Given this list of marker genes Mxd4, Npc2, Tspan32 (NCBI Gene Id 56845), Id3, Rgs2, Lck, Utrn, Cxcr4, Ms4a4b, Ccnd3, Uba52, Cd52, Fau, Ptpn22, Rgs16, Pold4, Cd83, Cd3d, Ube2b, Ift80, Cdkn1b, Cd3g, Tsc22d3 (NCBI Gene Id 14605), Hcst, Grap, Cox7a2l, Rgs10, Il7r, Eif3h, Cd84, Dusp1, Trbc2, Txnip, Evl, Ephx1, Smpdl3a, Stap1, Igf1r, Smad7, Stk17b, Btg2, Pfdn5, Ucp2, H1f4, Jun, Fos, Ypel3, H1f2, Arhgap31, Adcy7, Cd27, Pnrc1, Smc4, Thap3, Ripor2, Itpkb, Fyb1, Sh2d1a, Cd69, Ms4a6b, Limd2, Btg1, Zfp36l1, here is a description of the gene set: from publication Cui A, Huang T, Li S, Ma A, Pérez JL, Sander C, Keskin DB, Wu CJ, Fraenkel E, Hacohen N (PMID 38057668) species: Mus musculus Genes negatively differentially expressed in cell type: Treg upon treatment with cytokine: IL-2 in mouse lymph nodes in vivo. Mouse Gene Set: CUI_TREG_IL2_RESPONSE_DN Cytokines mediate cell-cell communication in the immune system and represent important therapeutic targets. A myriad of studies have highlighted their central role in immune function, yet we lack a global view of the cellular responses of each immune cell type to each cytokine. To address this gap, the authors created the Immune Dictionary, a compendium of single-cell transcriptomic profiles of more than 17 immune cell types in response to each of 86 cytokines (>1,400 cytokine-cell type combinations) in mouse lymph nodes in vivo. A cytokine-centric view of the dictionary revealed that most cytokines induce highly cell-type-specific responses. For example, the inflammatory cytokine interleukin-1β induces distinct gene programmes in almost every cell type. A cell-type-centric view of the dictionary identified more than 66 cytokine-driven cellular polarization states across immune cell types, including previously uncharacterized states such as an interleukin-18-induced polyfunctional natural killer cell state.